The following is a description of a gene set: Human Gene Set: HP_RENAL_NECROSIS Cell death (necrosis) affecting one or more parts of the kidney. species: Homo sapiens Renal necrosis, and this is the list of marker genes: LAMC2, LAMA3, LAMB3 (NCBI Gene Id 3914), CPT2, SLC22A12